The following is a description of a gene set: Mouse Gene Set: GOBP_NEGATIVE_REGULATION_OF_RHO_PROTEIN_SIGNAL_TRANSDUCTION Any process that stops, prevents, or reduces the frequency, rate or extent of Rho protein signal transduction. studied in species Mus musculus, and this is the list of marker genes: Ccdc125, Myoc, Met, Heg1, Abl2, Scai, Arhgap42, Rasip1, Itgb1, Tns3, Dlc1, Flcn, Bcl6, Kctd13 (potassium channel tetramerisation domain containing 13), Kank1, Kctd10, Arhgap35, Itga3, Cul3, Ripor1, Adra1b, Tnfaip1, Stmn1, Adra1a, Ripor2